Given this list of marker genes SMUG1, MBD4, DCTPP1 (NCBI Gene Id 79077), NT5C, NUDT16, NUDT18, NTHL1, DPYS, NT5C1A, GDA, DNPH1, SAMHD1, DERA, UNG, XDH (xanthine dehydrogenase), UPP2, TYMP, UPP1, PNP, DUT (NCBI Gene Id 1854), ADA, NT5C2, UPB1, TDG, NT5M, OGG1, NUDT15 (nudix hydrolase 15), NEIL1, NEIL2, DPYD, here is a description of the gene set: Human Gene Set: GOBP_DEOXYRIBONUCLEOTIDE_CATABOLIC_PROCESS studied in species Homo sapiens The chemical reactions and pathways resulting in the breakdown of a deoxyribonucleotide, a compound consisting of deoxyribonucleoside (a base linked to a deoxyribose sugar) esterified with a phosphate group at either the 3' or 5'-hydroxyl group of the sugar.